Given this list of marker genes SLC9A1, PPP3R2, CLEC7A, IGF1, AKAP5, PPP3CB, PPP3CA, LACRT, CHP2, SPPL3, CIB1, ERBB3, PTBP1, CHERP, PPP3CC, TNF, LMCD1, CAMTA1, AKAP6, PPP3R1, C10orf71, here is a description of the gene set: species: Homo sapiens Human Gene Set: GOBP_POSITIVE_REGULATION_OF_CALCINEURIN_MEDIATED_SIGNALING Any process that activates or increases the frequency, rate or extent of calcineurin-mediated signaling.